The following is a description of a gene set: Genes down-regulated in plasmacytoid dendritic cell 7d vs 0d in young adults (18-50) after exposure to FluMist, time point 7D from publication Nakaya HI, Wrammert J, Lee EK, Racioppi L, Marie-Kunze S, Haining WN, Means AR, Kasturi SP, Khan N, Li GM, McCausland M, Kanchan V, Kokko KE, Li S, Elbein R, Mehta AK, Aderem A, Subbarao K, Ahmed R, Pulendran B (PMID 21743478) Human Gene Set: NAKAYA_PLASMACYTOID_DENDRITIC_CELL_FLUMIST_AGE_18_50YO_7DY_DN Here we have used a systems biology approach to study innate and adaptive responses to vaccination against influenza in humans during three consecutive influenza seasons. We studied healthy adults vaccinated with trivalent inactivated influenza vaccine (TIV) or live attenuated influenza vaccine (LAIV). TIV induced higher antibody titers and more plasmablasts than LAIV did. In subjects vaccinated with TIV, early molecular signatures correlated with and could be used to accurately predict later antibody titers in two independent trials. Notably, expression of the kinase CaMKIV at day 3 was inversely correlated with later antibody titers. Vaccination of CaMKIV-deficient mice with TIV induced enhanced antigen-specific antibody titers, which demonstrated an unappreciated role for CaMKIV in the regulation of antibody responses. Thus, systems approaches can be used to predict immunogenicity and provide new mechanistic insights about vaccines. studied in species Homo sapiens, and this is the list of marker genes: OGFOD3, VASH2, TRGV5, APOE, PHLDB1, TEX30, RGS4, TBX3, OR2F1, GLTP, MAP3K9, PKD1L1-AS1, CLCN7, IGF2, MTFR1, MAGEA3, PDGFB, RTL10, GBP1, OSM (NCBI Gene Id 5008), TPSB2 (NCBI Gene Id 90686), GAS1 (growth arrest specific 1), TK1, RRP9, JAG2, TGM4, DAZ4, AP1M2, AR, MR1, CDC34, CRACDL, VAX2, AQP2, IL6, KLHDC3, MAST2, PPIL2, ALX3, SRPX2, NDRG4, DDIT3, LIMK1, TF, IRGQ, STAG3, NEUROG2, PRAMEF12, PRSS22, ELOVL2, DOK1, NCAPH2, CYP2B6, MED9, BRINP1, CSH1, CALCA, PTGER1, RARA, SERPINE1, OR5V1, CYLC1, SLC25A30, CLBA1, MAGEA10, ELF4, PCDHGC3, TMEM63A, RRAS2, PTPN3, HAPLN1, MT3, POLR2J2, KIF25, PTGS2, SLC26A6, KRTAP2-4, GSG1, PYCR3, MST1, STAP2, FBLN1, UBE2C, TPD52L1, CRHR1, PCBP3, CCR9, RTN2, C4A, ASMTL-AS1, LRP1, CLTC, NDE1, BGN, TRIM45, SNTB2 (syntrophin beta 2), BUB1B, JMJD7, RAB20, UBA6, ENGASE, METRN, LYST, PSEN2, NECTIN2, ANK3, CD1E, PLAUR, TNFRSF25, CYP2C9, PC, STARD8, TIMP3, CILP, SNAPC4, TPSAB1, SLC4A4, TCF25, SCGB2A2, ADTRP, DNAJC4 (NCBI Gene Id 93087), ZNF157, LGALS14, FKBPL, SLC35A2, DTX2, ABHD5, IRF6, WDFY3, MUC4 (NCBI Gene Id 55804), DAZ2, SHISAL1, ATP1B1, NSG1, SCAMP4, RDX, NCAM1, RSL1D1, LMTK2, PLEKHO2, ELN, CNGB1, HBEGF, RANBP1, HBA2, IFI30, CLTA, AKAP6, MT1E, PFN2, LAMA2, TNS1, CACNA1H, TRAFD1, PKNOX2, ZNF292, MBP, ERC1, ZBTB43, CIAO3, PPIA, VARS1, MYCT1 (MYC target 1), B3GNT3, F12, ZMIZ2, NAA11, ZSWIM8, TNFAIP6, FGF3, MTOR, ICOSLG, FOXF1, XIAP, PRDM8, ST20, NEU3, CYP2A7, KIRREL1, KAT5, DYRK1B, ITSN1, MTCL2, CHST4, NAGLU, BEX1, FBXO11, RHEB, GMDS, CHRDL1, SNAPC2, ALDH4A1 (aldehyde dehydrogenase 4 family member A1), KCNIP2, TMEM259, CRYBA4, CALY, AAR2, ADORA1, REPS1 (RALBP1 associated Eps domain containing 1), HS3ST2, SLC6A2, CACNA1I, CDCA4, MFNG, CABP1, ENOX1, TECTA, PDZK1IP1, KMT5A, P2RX2, CEND1, SPX, KHK, NKX2-2, ZC3HAV1, ZFAND3, LMF1, DCUN1D4, HK2, CLPS, TNNC2, APLP1, MEX3D, GUCA1A (guanylate cyclase activator 1A), BIRC5, LDB3, RC3H2, RFC1, PCDHA10, ANAPC10, CYP4F8, FGF12, CHAT, GOLIM4, COL6A1, TREM2, KRT6B, ZNF467, HMGCL, DUX4L7, CYP2A6, CSF3, CHRNG, EMP1, TIMM17A (translocase of inner mitochondrial membrane 17A), FBXL8, RCC1, SIM1, CACNA1E, CAMK2G, SDK2, FCAR, CACNA1A, MAD1L1, PLPBP, LTBP4, SMR3B, SMTN, CXADR, HK1, KLK10, MED27, PIK3CB, THAP7, AKAP13, SOX15, BRPF1, SLC2A2, TEX15, AKR1C4, CFHR5, ALK, POLR3D, KLHL35, COTL1, GPR135 (G protein-coupled receptor 135), CRYGD, KIAA0040, FGL1, TBC1D1, CFAP410 (cilia and flagella associated protein 410), GAL, CYB561, ATG2A, SAA2, SERHL2, IGFBP5 (NCBI Gene Id 3488), DPT, PURA, FH, IL6ST, RNF126 (ring finger protein 126), KCND3, CASP4, DDX11, C1S, HSPA6, ADAM19, STMN1, NLRP1, MTF1, MEGF6, GAREM1, CEBPA, RAB23, PLXNA2, MFSD5, RPL35A, EFHD1, CSNK1E, PWP2, MPZL1, KLRG1, HS3ST1, IER2, ZNF606, PAX6, CACFD1, PDE2A, STBD1, PNMT, HES1, KIAA1614, IL2, SP2, KSR1, CDH4, HTR1D, POU3F4, SIL1, RUNX1, TNXB, DIO2, AAK1, CCDC71, KIF22, ASPHD1, CRB1, SRF, SLC39A4, NPHP4, FCN1, LCMT2, NINL, TAB1, ASH1L, MAP3K19 (NCBI Gene Id 80122), ARHGEF17, GPR32, PTGS1, SLC16A5, ARHGAP6, ASIC1, IL15 (interleukin 15), FBLN5 (NCBI Gene Id 11268), SDHB, VPS28, SFTPC, MMP25, CLEC4M, CHPF2, EHD1, TACR1, METTL4, CCL25, TUBG1, TNFRSF10C, SEMA6B (NCBI Gene Id 56991), APPBP2 (amyloid beta precursor protein binding protein 2), SMAD6, SENP6, OBSCN, ADARB1, PRRX2, DUX4 (NCBI Gene Id 649941), RFX1, GYPB, ERG (ETS transcription factor ERG), FCGR1A, CCL5, PCCA (NCBI Gene Id 5095), HELLS, TMX4, ACY1, CYP2C8, SSBP2, HAO2, LIMCH1, LAMB1, ATF7IP, VAV3, KLHDC10, HBA1, SPNS1, SERPIND1 (NCBI Gene Id 3053), PHKG1, TRIM31, CDKN2A-AS1, MRPS12, DAZ1, EPB41L3, DKK4, FAIM2, KLK1, ABCA11P, VDR, SIGLEC7, AKAP8L, PDLIM5, TUBA4A, RAB3B, SLC11A1, STAB2 (stabilin 2), ASCL1, ALX1, ITGA6, IQCC, NRP2, TP73, TCEAL2, PYY, KLHL20, UST, SKAP2, POGLUT2, RTN1, ALAS2, CCK, CADM4, CAMK1, GSPT1, CALB1, YIPF6, SOD3, CDA, GPER1, HSD17B8, EMC9, ITIH4, GNAO1, VWA7, BTNL8, GAS7, SEMA7A, NCLN, FGF5, C15orf39, PER2, GPR162, CYP2C18, DCT, MSL3, BACH1, PDHA2, ZNF189, MCM10, MEGF8, LAT, PNMA8A, THTPA, TM9SF1, C4B, ADAM8, GORASP1, B9D1, ITIH2 (NCBI Gene Id 3698), AMHR2, GATA1, PDGFRA, PAEP, CALR, SLC2A14, DCAF4, TEX11, PPARD, RIF1, NR2E3, NTRK2, HOXB5, RGS9, EPN3 (epsin 3), FRMD4A, CHAF1A, AVPR1A, KLHL24, DOCK6 (dedicator of cytokinesis 6), BRF1, NECTIN3, GDF15, KLHL22, TGOLN2, CHFR, SLC24A2, CKB, GATAD1, ITGA2B, BBS9, MPIG6B, PTPRH, OGN, SDF4, DLGAP4, GPR22, TNFSF14, MAP2K5, ASAP3, AKIP1, MYL6, SPINK5, ZNF324, JAK3 (NCBI Gene Id 3718), PPDPF (pancreatic progenitor cell differentiation and proliferation factor), GP2, DLAT, TFCP2L1, SFI1, PIP4K2B, CDC42EP4, L1CAM, PDE4D, TRIM23, ME1, FADD, LMNA, GALNT6, MAFK, OCA2, NMT2, CDC14B, CD300C, MYCN, SLC14A2, KIR3DL1, CD79B, ING2, ITGA3, TLR8, DFFB, SNCA, TBK1, INO80D, CAPN10, DUX4L4, PRPF31, PBX2, SLCO3A1, ELK1, SRGAP3, NCR2 (natural cytotoxicity triggering receptor 2), CEACAM6, SKIC2, CDH15, IMPG1, FN1, HMOX2, DLG5, PPP2R5A, JMJD7-PLA2G4B, CPT1B, MICAL2, DLEC1, TNXA, COL11A2, EXOSC4, WNT6, IGFALS, ASL, RRP12, MSRB2, H1-1, ETV1, CHIA (NCBI Gene Id 27159), TRBV10-2, RAD23B, NDRG2, IGHG1, NDEL1, SLC16A8, ART4, MFAP5, CD28, KCTD14, RAI14, SLC19A1, CCNE2, VEGFA, RNFT1, TAF6L, CTNND2, CDKN2A, IMPDH1, CHD4, ACP5, CHD5, CUL7, ZFR2, GCHFR, ESR1, SIGLEC8, HOXD13, LRP5L, ABCF2, CRYBG2, MLXIPL, PRMT7, PFKFB4, KPLCE, STARD3, FLNC, P3H3, TCN2, SULT2B1, EYA4, QTRT1, HSD11B1, WIZ, HCN4, CDC42EP3, CASQ1, PRKD2, MIF, SLC6A8, CMKLR2, ZDHHC11, PTAFR, TMEM131L, FKBP6, CSNK1G1, PSRC1, RHD, MT1G, SLC6A11, CSNK1G2, HOOK1, GCGR, SPACA1, FCGR2C, PLEC, TOM1L2, TCTN2, INHBB, CAMK2B, SMR3A, UCN, HRK, ADCY6, BDKRB2, COL7A1, PLA2G3, CD24, CWC25, CDSN, SMG7 (NCBI Gene Id 9887), KCTD5, RPS28, RASSF4, RARB, GIMAP5, MKI67, CLCN4, RAD51B, SKI, FNDC11, SNTB1, OR2C1, SH2D3A, CALML5, ADGRG1, MRPL2, NAA40, DDX31, USP46, RANBP3, COL4A3, FOSL2, RABEP2, LGI2, HMGB3, RPS6, JRK, PHYHIP, BLVRA, CORO1B (NCBI Gene Id 57175), KDM6B, NUP98, USP32, PLXNA1, IGF1, MAPK12, LHPP, TLE4, FOXN1, TSC22D4, MXRA8, MYCNOS, ZCCHC14, NSD2, FABP2, APOM, SYNM, ST6GALNAC2, CYP3A4 (cytochrome P450 family 3 subfamily A member 4), COMMD4, RIPK4, IL1B (NCBI Gene Id 3553), MOG, ZNF76, SLN, ETV7, OSGIN1, HK3 (hexokinase 3), FXYD6, FOXP1, DENND2A, CPNE6, TTC38, EFCC1, DUX4L6, SLC22A18AS, SAPCD1, RRP15, CDC42, SYP, ZNF551 (zinc finger protein 551), TCP11L1, ELSPBP1, PRR5, ARHGAP26, ITPKC, TBX1, GABARAPL1, SLC25A22, SLC17A7, TAT, RNF122, ACAN, PLSCR1, PDLIM4 (NCBI Gene Id 8572), CEACAM1, DNAI1, SCARB1, SPTB, IFT122, DHX8, IER3, ST7L, NR0B1, FZD10, MUC1, NUAK2, GABRG2, TERT, TUBB1, SCNN1A (sodium channel epithelial 1 subunit alpha), SNRPN, CXCL1 (NCBI Gene Id 2919), RYK, OGFOD2, RBBP4, SEMA3F, WFS1, CACNB3, MAPKAPK5-AS1, SOX9 (NCBI Gene Id 6662), ADCY3, PVR, SAA1, GNA11, SEZ6L, NOTCH3, DNAJC1, DUX4L5, MB, ZNF174, OBSL1, AZGP1, SLC2A3 (NCBI Gene Id 94827), MYB, MSH6, TLN2, EPN1 (NCBI Gene Id 29924), MCOLN3, BPNT1 (NCBI Gene Id 10380), PCGF1, PEX19, GPR137, TNFAIP2, EHBP1L1, ACHE, GGA1, DHX34, CERS4, OR2F2, CYP2E1, HEG1, PHF3, ZBTB32, MTHFR, ID2, ISL1, ZFHX2, TRA2A, RBM38, LARP6, LRRC31, LPCAT4, DUS2, PBXIP1, GMEB1, ZNF154, KPTN, SAMD9, RNASE2 (NCBI Gene Id 6036), NR1I2, NPEPL1, GPR68, DPYSL4, POLG, CNPY4, SLC35C1, MARCKS, CDK3, SCN2A, MUC13, DAZ3, DGKG, MYBPC2, NKX2-5, EXOG, CHAD, KIR2DL5A, TSPAN9, ARHGEF11, ZNF536, WDR76, SLC25A37, TBCD, UBE2H, YBX1, GHSR, MAST4, SOCS1, VNN2, PAWR, SRCAP, CACNB2, DTNA, LLGL2, TNFRSF10B, F11, SLC7A8, DOCK5, OR12D3, PRIM1, TLX2, H2AC15, ATAD2, EXOC7, POMC, GATA2, GRAP2, MATN1, IL27RA, GHRH, ITPK1, ITGB4, TROAP, INS-IGF2, JADE3, APOC2 (NCBI Gene Id 344), GART, EPHA1, ACVR1B, RBPMS, PRELP, SDC1, EXPH5, CFLAR, ANGPT1, INTS5, PTPRD, PDE4A, ZSCAN31, CHKB-CPT1B, PEX10, TNPO2, GNB5, BIK, ABCC6, NPAT, DMXL2, TUSC2, SCLY, LRRC61, LEFTY1, VPREB3, CRLF1 (NCBI Gene Id 9244), NHERF2, PRAMEF11, DMAC2L, CARD10, BOP1, TLL2, SLC12A3, SLC2A4RG, RHBDL1, MEAK7, EXOSC2, CEP76